Given this list of marker genes IREB2 (NCBI Gene Id 3658), NANS, DHCR24, SPTAN1, SLITRK2, UFC1, NDUFA9, RERE, CNTNAP2, FTH1, TMEM147, NFU1, SRPK3, NDUFA2, RAB11B, ZNF335, TUBB2A, BCL11B, PCLO, RNU4-2, GABRG2, CTNNA2, KIF26A, PI4K2A, ESAM, NAA80, CLP1, PPP3CA, CRLS1, PYCR2, DNM1, ARF1, WARS1, KCNT2, ASNS, WDR45B, NDUFA6, BRPF1, MTOR, ASXL2, PIGL, DHX9, NAA60, CHMP1A, MPV17, AHDC1, here is a description of the gene set: Human Gene Set: HP_REDUCED_CEREBRAL_WHITE_MATTER_VOLUME Reduced cerebral white matter volume An abnormally low volume of the white matter of the brain. species: Homo sapiens